The following is a description of a gene set: from publication Meinhold-Heerlein I, Bauerschlag D, Hilpert F, Dimitrov P, Sapinoso LM, Orlowska-Volk M, Bauknecht T, Park TW, Jonat W, Jacobsen A, Sehouli J, Luttges J, Krajewski M, Krajewski S, Reed JC, Arnold N, Hampton GM (PMID 15558012) studied in species Homo sapiens Human Gene Set: MEINHOLD_OVARIAN_CANCER_LOW_GRADE_DN Genes down-regulated in low grade (LMP and G1) serous ovarian carcinomas vs the higher grade invasive tumors (G2 and G3). Profiles of gene transcription have begun to delineate the molecular basis of ovarian cancer, including distinctions between carcinomas of differing histology, tumor progression and patient outcome. However, the similarities and differences among the most commonly diagnosed noninvasive borderline (low malignant potential, LMP) lesions and invasive serous carcinomas of varying grade (G1, G2 and G3) have not yet been explored. Here, we used oligonucleotide arrays to profile the expression of genes in a series of 57 predominantly stage III serous ovarian adenocarcinomas from 52 patients, eight with borderline tumors and 44 with adenocarcinomas of varying grade. Unsupervised and supervised analyses showed that LMP lesions were distinct from high-grade serous adenocarcinomas, as might be expected; however, well-differentiated (G1) invasive adenocarcinomas showed a strikingly similar profile to LMP tumors as compared to cancers with moderate (G2) or poor (G3) cellular differentiation, which were also highly similar. Comparative genomic hybridization of an independent cohort of five LMP and 63 invasive carcinomas of varying grade demonstrated LMP and G1 were again similar, exhibiting significantly less chromosomal aberration than G2/G3 carcinomas. A majority of LMP and G1 tumors were characterized by high levels of p21/WAF1, with concomitant expression of cell growth suppressors, gadd34 and BTG-2. In contrast, G2/G3 cancers were characterized by the expression of genes associated with the cell cycle and by STAT-1-, STAT-3/JAK-1/2-induced gene expression. The distinction between the LMP-G1 and G2-G3 groups of tumors was highly correlated to patient outcome (chi(2) for equivalence of death rates=7.681189; P=0.0056, log-rank test). Our results are consistent with the recent demonstration of a poor differentiation molecular 'meta-signature' in human cancer, and underscore a number of cell-cycle- and STAT-associated targets that may prove useful as points of therapeutic intervention for those patients with aggressive disease., and this is the list of marker genes: STAT1 (signal transducer and activator of transcription 1), MCM6, CCNB2, KIF14, PTP4A2, MRPL9 (NCBI Gene Id 65005), NCK1, FASN, BAP1, JTB, SNRPB, TUBA1B, UVRAG, CFL1, STARD7, PCCB, TPX2, RHEB, RAD21